Given this list of marker genes IRF6, ADAR, IRF7, IRF1, IRF2, IFNA1, CCL5, IFNB1, IRF9, here is a description of the gene set: The cellular innate immune system is essential for recognizing pathogen infection and for establishing effective host defence. But critical molecular determinants responsible for facilitating an appropriate immune response-following infection with DNA and RNA viruses, for example-remain to be identified. Here we report the identification, following expression cloning, of a molecule (STING; stimulator of interferon genes) that appears essential for effective innate immune signalling processes. It comprises five putative transmembrane regions, predominantly resides in the endoplasmic reticulum and is able to activate both NF-kappaB and IRF3 transcription pathways to induce expression of type I interferon (IFN-alpha and IFN-beta ) and exert a potent anti-viral state following expression. In contrast, loss of STING rendered murine embryonic fibroblasts extremely susceptible to negative-stranded virus infection, including vesicular stomatitis virus. Further, STING ablation abrogated the ability of intracellular B-form DNA, as well as members of the herpesvirus family, to induce IFN-beta, but did not significantly affect the Toll-like receptor (TLR) pathway. Yeast two-hybrid and co-immunoprecipitation studies indicated that STING interacts with RIG-I and with SSR2 (also known as TRAPbeta), which is a member of the translocon-associated protein (TRAP) complex required for protein translocation across the endoplasmic reticulum membrane following translation. Ablation by RNA interference of both TRAPbeta and translocon adaptor SEC61beta was subsequently found to inhibit STING's ability to stimulate expression of IFN-beta. Thus, as well as identifying a regulator of innate immune signalling, our results imply a potential role for the translocon in innate signalling pathways activated by select viruses as well as intracellular DNA. Human Gene Set: ISHIKAWA_STING_SIGNALING Primary innate immune response genes induced in 293T cells (embryonic kidney) by overexpression of STING (TMEM173). studied in species Mus musculus from publication Ishikawa H, Barber GN (PMID 18724357)